The following is a description of a gene set: Mouse Gene Set: GOCC_ANGIOGENIN_PRI_COMPLEX species: Mus musculus A stable heterodimer of angiogenin and placental ribonuclease inhibitor; interaction between angiogenin and PRI prevents angiogenin binding to its receptor to stimulate angiogenesis., and this is the list of marker genes: Ang5 (NCBI Gene Id 503844, angiogenin, ribonuclease A family, member 5), Ang6, Ang, Gm28729, Ang4, Rnh1, Ang2